The following is a description of a gene set: The chemical reactions and pathways resulting in the formation of ceramide oligosaccharides carrying in addition to other sugar residues, one or more sialic acid residues. Mouse Gene Set: GOBP_GANGLIOSIDE_BIOSYNTHETIC_PROCESS species: Mus musculus, and this is the list of marker genes: St8sia4, St8sia3, St8sia2, St6galnac5, St3gal1, B4galt5, St3gal2, B4galnt1, St6galnac3 (NCBI Gene Id 20447), St3gal3, 6430550D23Rik, St6galnac1, B3galt4, St6galnac6, St6galnac4, B4galt6 (NCBI Gene Id 56386), St8sia6